The following is a description of a gene set: studied in species Homo sapiens Human Gene Set: HP_ABNORMALITY_OF_VITAMIN_K_METABOLISM Abnormality of vitamin K metabolism Vitamin K is a fat-soluble vitamin with a role in promoting the coagulation cascade., and this is the list of marker genes: AMACR, EFL1, SBDS, HLA-DQB1, SEMA4D, HLA-DQA1, DZIP1L, GPR35, DNAJC21, PKHD1, TCF4 (transcription factor 4), MST1, TJP2